The following is a description of a gene set: studied in species Homo sapiens Human Gene Set: KEGG_MEDICUS_VARIANT_AML1_ETO_FUSION_TO_PU.1_MEDIATED_TRANSCRIPTION AML1-ETO fusion to PU.1-mediated transcription. Pathway ID: N00112. Pathway type: Variant. Pathway class: nt06275 Acute myeloid leukemia. Pathway Definition from KEGG: AML1-ETO -| SPI1 => (CD14,ITGAM,FCGR1A), and this is the list of marker genes: ITGAM (integrin subunit alpha M), RUNX1, SPI1, CD14, FCGR1A